The following is a description of a gene set: Mouse Gene Set: GOBP_LIPOPROTEIN_CATABOLIC_PROCESS The chemical reactions and pathways resulting in the breakdown of any conjugated, water-soluble protein in which the covalently attached nonprotein group consists of a lipid or lipids. studied in species Mus musculus, and this is the list of marker genes: Notum, Apob, Apoe, Abhd17c, Lyplal1, Atm, Lypla1, Abhd17b, Lipa, Abhd13, Abhd17a, Abhd12, Abhd10, Apoc2, Ctsd (NCBI Gene Id 13033), Ldlr, Lypla2, Ppt1